Given this list of marker genes GTF3C5, MTOR, TSPYL2, DHX33, BEND3 (BEN domain containing 3), BNC2, MACROH2A1, ALKBH2, MAF1, BNC1 (NCBI Gene Id 646), here is a description of the gene set: Binding to a DNA sequence encoding a ribosomal RNA. species: Homo sapiens Human Gene Set: GOMF_RDNA_BINDING